Given this list of marker genes PLCG1, EGFR, ERBB2, EGF, here is a description of the gene set: Activation of PLCG1 signaling is observed only in the presence of ERBB2:EGFR heterodimers, with PLCG1 binding to phosphorylated tyrosine Y992 and Y1173 in the C-tail of EGFR, and potentially Y1023 in the C-tail of ERBB2. studied in species Homo sapiens Reactome Pathway: PLCG1 events in ERBB2 signaling part of: Signaling by ERBB2